Given this list of marker genes MORC2, SCD5, ELOVL2, ACSF3, HSD17B3, SLC27A2 (solute carrier family 27 member 2), SLC27A3, ACACA, HTD2, FASN, ELOVL6 (ELOVL fatty acid elongase 6), HACD4, ACSL3, TECR, HSD17B8, SCD, ACSBG2 (acyl-CoA synthetase bubblegum family member 2), HACD1, OLAH (oleoyl-ACP hydrolase), ELOVL3, PPT2, HSD17B12, ACSL6, ELOVL1, HACD2, ELOVL5, PPT1, ACSL5, ELOVL7, ACSL4, HACD3, ELOVL4, CBR4, ACLY, ACSL1, TECRL, ACSBG1, here is a description of the gene set: studied in species Homo sapiens part of: Fatty acid metabolism Reactome Pathway: Fatty acyl-CoA biosynthesis Fatty acyl-CoA biosynthesis involves following steps:<BR> -Palmitate synthesis catalyzed by Acetyl-CoA carboxylase and Fatty acid synthase<BR>-Conversion of palmitic acid to long chain fatty acids and<BR>-Conversion of long chain fatty acids to fatty acyl-CoA by acyl-CoA synthases.<BR>